The following is a description of a gene set: Any process that modulates the frequency, rate, or extent of the chemical reactions and pathways resulting in the breakdown of lipids. studied in species Mus musculus Mouse Gene Set: GOBP_REGULATION_OF_LIPID_CATABOLIC_PROCESS, and this is the list of marker genes: Etfbkmt, Pnpla2, Prkaa1, Prkcd (NCBI Gene Id 52581), Mtor, Idh1, Dbi, Crtc3, Ins1, Gimap5, Lonp2, Sirt6, Acsl5, Apoc3, Angptl3, Hcar1, Sctr, Mfsd2a, Fgf21, Adora1, Apoa5, Mtln, Cpt1a, Abcb11, Fmc1, Irs2, Aadac, Plin5, Tnf, Apoc2, Bscl2, Abhd5, Irs1, Pik3cg, Daglb, Sorl1, Cidea, Acacb, Pde3b, Abcd2 (ATP-binding cassette, sub-family D member 2), Adra2a, Sct, Alk (NCBI Gene Id 11682), Apoh, Enpp7, Hpgd, Ldlr, Ins2, Akt1, Apoa2, Twist1, Apoa4, Clstn3, Il1b, Tysnd1, Fabp1, Mlycd, Gimap3, Gpld1, Akt2, Endou, Prkce, Cidec, Obp2a, Thra, Abcd1 (ATP-binding cassette, sub-family D member 1), Apoc2l, Rarres2, Cnr1, Hcar2, Apoc1, Scarb1 (scavenger receptor class B, member 1)